The following is a description of a gene set: Any process that modulates the frequency, rate or extent of striated muscle contraction. Mouse Gene Set: GOBP_REGULATION_OF_STRIATED_MUSCLE_CONTRACTION species: Mus musculus, and this is the list of marker genes: Jup, Trpm4, Atp1a2, Strit1, Casq1, Akap6, Adra1a, Grcc10, Cacna1h, Sri, P2rx4, Ank2, Pde4d, Scn5a, Rgs2, Mylk2, Dsp, Nr4a1 (NCBI Gene Id 15370), Adora1, Dlg1, Actn3, Trpv4, Tnni3, Myh7, Cav3 (NCBI Gene Id 12391), Tnni3k, Adra1b, Dsc2, Bmp10, Fgf13, Atp2a2, Stc1, Pln, Sumo1 (small ubiquitin-like modifier 1), Ryr2, Hdac4, Ehd3, Tmem38a, Hcn4, Ccn2, Kcnq1, Ctnna3, Rangrf, Nkx2-5, Hsp90aa1, Slc8a1, Grk2, Fkbp1b, Myh7b, Gata4, Scn10a, Akap9, Pde5a (NCBI Gene Id 242202), Cacna1c, Tmem38b, Fxyd1, Dsg2, Casq2, Nppa, Atp2a1, Kbtbd13, Chga, Adcy10 (NCBI Gene Id 73777), Adrb1 (NCBI Gene Id 11554), Scn4a, Rem1, Kcnj2, Smtn (NCBI Gene Id 29856), Dmpk, Cav1 (caveolin 1, caveolae protein), Smad7, Dmd, Prkd1, Calm3, Gja5 (gap junction protein, alpha 5), Myl3, Ucn, Atp1a1, Calm1, Agrn, Tnnt3, Slc8a3, Ace2, Pkp2, Arg2, Bin1, Zc3h12a, Calm2, Atp1b1, Slc9a1, Rnf207